Given this list of marker genes Mvb12a (multivesicular body subunit 12A), Nedd4, Tgfb1, Gprasp1, Pcsk9, Sh3glb1, Mtmr2, Capn1, Kif16b, Apoe, Cdk5, Lgmn, Itch, Becn1, Snx25, Uvrag, Dtx3l, Abca2, Hamp, Ptpn1, Hamp2, Laptm5, Git1, Pik3r4, Anxa2, Smurf1, Becn2, Nedd4l, Znrf3, Rnf43, Furin, Mylip (myosin regulatory light chain interacting protein), here is a description of the gene set: The chemical reactions and pathways resulting in the breakdown of a receptor molecule, a macromolecule that undergoes combination with a hormone, neurotransmitter, drug or intracellular messenger to initiate a change in cell function. Mouse Gene Set: GOBP_RECEPTOR_CATABOLIC_PROCESS studied in species Mus musculus